Given this list of marker genes UBE2L3, UBA1, TH, CCNE2, MIR26A1, UBE2G1, UBE2L6, MIR34B, MIR34C, MAPK14, DDC, MIR375, MIR212, SYT11, SEPTIN5, MIR19B1, UBA7, MIR485, MIR1294, MIR26A2, MIR873, PINK1, MIR19B2, SNCA, MIR136, EPRS1, MIRLET7G, MIR503, MIR128-2, MIR433, MIR431, CASP6 (NCBI Gene Id 839), UBE2J1, ATXN2, MIR18A, MIR26B, GPR37 (G protein-coupled receptor 37), MIR370, UBE2G2, MIR409, MIR16-2, UBE2J2, MIR338, MIR128-1, MAPK12, SNCAIP, CASP7, CASP3, MIR127, CASP2, CASP9, MIR132, MIR30A, LRRK2, UBB, HTRA2, SLC6A3, APAF1, MIR1224, MIR30E, PARK7, MIR4448, PRKN, MAPK11, MAPK13, MIR10A, CCNE1, MIR195, CYCS, UCHL1, MIR19A (NCBI Gene Id 406979), here is a description of the gene set: species: Homo sapiens Human Gene Set: WP_PARKINSONS_DISEASE_PATHWAY Parkinson's disease pathway